The following is a description of a gene set: Human Gene Set: MIR640 Genes predicted to be targets of miRBase v22 microRNA hsa-miR-640 in miRDB v6.0 with MirTarget v4 prediction scores > 80 (high confidence targets). from publication Chen Y, Wang X (PMID 31504780) studied in species Homo sapiens, and this is the list of marker genes: REEP5, TNPO1, NELL1, PUS10, IGF2BP3, KLHL12, FAM72A, PHLDA1, SLC25A46, GID8, ABI3BP, FAM72B, SVOP, ZBTB24, TRIM33, WDR43, ZFP91, COX7A2, ING5, ADPRM, HNRNPH3, DCAF6, TPT1, VLDLR, FAM72C, TADA2B, SPAM1, UTP3, ZNF157, ZSWIM5, BNIP3, SF3B1, ISCA1 (iron-sulfur cluster assembly 1), PPP6R3, TKTL1, KATNA1, WARS2, HIF1A, GIGYF2, TENT4B, PTPN9, RNF168, GPM6B, CCNG1, DMAC1, MARK2, EXOSC3, GNPDA1, FAM72D, USH2A, SPINK8, LSM12, PLPP3, TM9SF3, SOX6, MAP3K1